The following is a description of a gene set: studied in species Mus musculus Mouse Gene Set: GOCC_SMC5_SMC6_COMPLEX A conserved complex that contains a heterodimer of SMC proteins (Smc5p and Smc6p, or homologs thereof) and several other proteins, and is involved in DNA repair and maintaining cell cycle arrest following DNA damage. In S. cerevisiae, this is an octameric complex called Mms21-Smc5-Smc6 complex, with at least five of its subunits conserved in fission yeast and humans., and this is the list of marker genes: Smc5 (structural maintenance of chromosomes 5), Smc6, Nscme3l, Nsmce2, Nsmce1, Nsmce3, Nsmce4a, Eid3